Given this list of marker genes Klf6, Hspa1a, Jun, S100a10, Junb, Ubc, Dnaja1, Hspa1b, Btg2, Hspa8, Fos, Jund, Icos, Fosb, Dusp1, here is a description of the gene set: from publication Cui A, Huang T, Li S, Ma A, Pérez JL, Sander C, Keskin DB, Wu CJ, Fraenkel E, Hacohen N (PMID 38057668) studied in species Mus musculus Mouse Gene Set: CUI_T_CELL_GD_OSM_RESPONSE_DN Cytokines mediate cell-cell communication in the immune system and represent important therapeutic targets. A myriad of studies have highlighted their central role in immune function, yet we lack a global view of the cellular responses of each immune cell type to each cytokine. To address this gap, the authors created the Immune Dictionary, a compendium of single-cell transcriptomic profiles of more than 17 immune cell types in response to each of 86 cytokines (>1,400 cytokine-cell type combinations) in mouse lymph nodes in vivo. A cytokine-centric view of the dictionary revealed that most cytokines induce highly cell-type-specific responses. For example, the inflammatory cytokine interleukin-1β induces distinct gene programmes in almost every cell type. A cell-type-centric view of the dictionary identified more than 66 cytokine-driven cellular polarization states across immune cell types, including previously uncharacterized states such as an interleukin-18-induced polyfunctional natural killer cell state. Genes negatively differentially expressed in cell type: γδ T cell upon treatment with cytokine: OSM in mouse lymph nodes in vivo.